The following is a description of a gene set: Human Gene Set: REACTOME_NEUROFASCIN_INTERACTIONS Neurofascin interactions species: Homo sapiens, and this is the list of marker genes: SDCBP, DCX (NCBI Gene Id 1641), CNTNAP1, NFASC, ANK1, CNTN1, NRCAM